Given this list of marker genes Cdc5lrt5, Snrnp200, Snrpe, Sf3a1, Prpf19, Cdc5l (NCBI Gene Id 71702), Cwc22, Yju2, Aqr, Snrpb, Snrpd1, Prpf31, Smu1, Cdc40, Snrpb2, Lsm8, Prpf6, Snrpc, Magohb, Bud13, Lsm4, Cwc22rt1, Cwc22rt5, Cdc5lrt9, Cwc22rt6, Tex16, Ddx46, Luc7l3, Cwc25, Syf2, Snw1, Plrg1, Ppil1, Lsm7, Lsm3, Snrpn, Prpf40b, Rnf113a1, Eif4a3l1, Snip1, Sart1, Cwc22rt4, Htatsf1, Rnf113a2, Snrpf, Eif4a3, Snrpg, Cdc5lrt1, Isy1, Prpf4, Sf3b2, Cdc5lrt7, Tfip11, Phf5a, Prpf3, Dhx16, Snrpd2, Dhx8, Cwc22rt3, Mfap1a, Cdc5lrt4, Cwc22rt2, Yju2b, Snrpa1, Lsm6, Sf3b4, Sf3b6, Txnl4a, Ddx42, Cwc27, Cdc5lrt10, U2af2, Cdc5lrt8, Prpf18, Lsm2, Cdc5lrt6, Gcfc2, Prpf40a, Bcas2, Srrm2 (serine/arginine repetitive matrix 2), Prpf38a, Dhx15, Ppie, Sf3b1, Snu13, Cwc15, Snrpert, Casc3, Prpf8, Ccdc12, Wbp4, Bud31, Luc7l2, Rbmx2, Crnkl1, Rbm22, Rbm8a2 (RNA binding motif protein 8A2), Snrnp70, Cwc22rt7, Sf3a3, Snrnp40, Sf3a2, Eif4a3l2, Mfap1b, Eftud2, Ik, Sf3b5, Rbm8a, Prpf39, Sf3b3, Xab2, Zmat2, Snrpd3, Lsm5, Luc7l (NCBI Gene Id 72300), here is a description of the gene set: species: Mus musculus Mouse Gene Set: GOCC_U2_TYPE_SPLICEOSOMAL_COMPLEX Any spliceosomal complex that forms during the splicing of a messenger RNA primary transcript to excise an intron that has canonical consensus sequences near the 5' and 3' ends.